The following is a description of a gene set: The process in which the anatomical structure of the cerebellar granular layer is generated and organized. The granular layer is the innermost layer of the cerebellar cortex. This layer contains densely packed small neurons, mostly granule cells. Some Golgi cells are found at the outer border. Granule neurons send parallel fibers to the upper molecular layer, where they synapse with Purkinje cell dendrites. Mossy fibers from the pontine nuclei in the white matter synapse with granule cell axons, Golgi cell axons and unipolar brush interneuron axons at cerebellar glomeruli in the granule cell layer. studied in species Mus musculus Mouse Gene Set: GOBP_CEREBELLAR_GRANULAR_LAYER_MORPHOGENESIS, and this is the list of marker genes: Serpine2 (serine (or cysteine) peptidase inhibitor, clade E, member 2), Grid2, Ulk1, Wnt7a, Atp2b2, Kndc1, Mtpn, Ophn1, Kif14, Nrxn1, Cbln1, Prox1, Nfix